The following is a description of a gene set: from publication Bystrykh L, Weersing E, Dontje B, Sutton S, Pletcher MT, Wiltshire T, Su AI, Vellenga E, Wang J, Manly KF, Lu L, Chesler EJ, Alberts R, Jansen RC, Williams RW, Cooke MP, de Haan G (PMID 15711547) species: Mus musculus Genes whose expression is coregulated with that of IL3RA in hematopoietic stem cells (HSC). We combined large-scale mRNA expression analysis and gene mapping to identify genes and loci that control hematopoietic stem cell (HSC) function. We measured mRNA expression levels in purified HSCs isolated from a panel of densely genotyped recombinant inbred mouse strains. We mapped quantitative trait loci (QTLs) associated with variation in expression of thousands of transcripts. By comparing the physical transcript position with the location of the controlling QTL, we identified polymorphic cis-acting stem cell genes. We also identified multiple trans-acting control loci that modify expression of large numbers of genes. These groups of coregulated transcripts identify pathways that specify variation in stem cells. We illustrate this concept with the identification of candidate genes involved with HSC turnover. We compared expression QTLs in HSCs and brain from the same mice and identified both shared and tissue-specific QTLs. Our data are accessible through WebQTL, a web-based interface that allows custom genetic linkage analysis and identification of coregulated transcripts. Mouse Gene Set: BYSTRYKH_HEMATOPOIESIS_STEM_CELL_IL3RA, and this is the list of marker genes: Bcap31, Rac1, Ccnd3, Sertad1, Epha6, Kmt2a, Vegfb, Guca1a, Pcdha4